The following is a description of a gene set: species: Homo sapiens Human Gene Set: GOCC_CLATHRIN_COATED_ENDOCYTIC_VESICLE A clathrin-coated, membrane-bounded intracellular vesicle formed by invagination of the plasma membrane around an extracellular substance., and this is the list of marker genes: AP2S1, SCARB2, AVPR2, CEMIP, EPGN, VAMP2, APOE, IGF2R, EREG, AVP, EPS15, TFRC, HBEGF, EGFR, CTLA4, M6PR, STON1, DVL2, STON2, HLA-DRA, LDLRAP1, TBC1D5, SGIP1, BTC, FZD5, HLA-DRB4, SFTA3, EGF, LRP2, CD3G, AP2A2, VAMP7, INPP5F, RAB35, HLA-DQA2, VAMP8 (vesicle associated membrane protein 8), SFTPB, FCGR1A, ADRB2, SFTPD, HLA-DQB1 (major histocompatibility complex, class II, DQ beta 1), TGOLN2, PICALM, WNT5A, HLA-DPB1, VAMP4, SFTPA1, CD74, HLA-DPA1, SFTPA2 (surfactant protein A2), MYO1E, HLA-DQB2, APOB, AP2A1, BTBD8, SLC2A8, CFTR, FZD2, SLC18A3, CLTCL1, RAB5A, IL7R, CLTA, ROR2, HLA-DQA1, CD9, HLA-DRB3, MYO6, LDLR, AP2M1, TF, SH3GL2, CD4, TGFA, CD3D, SYT9, CLTC, KIAA0319, SYT2, HLA-DRB1, TYRP1, AP2B1, AREG, FCGR1BP, SFTPC, CLTB, FZD4, CHRM2, VAMP3, CPNE6, HLA-DRB5, SYT1, LMBRD1, CD207